The following is a description of a gene set: Genes negatively differentially expressed in cell type: cDC2 (conventional dendritic cell type 2) upon treatment with cytokine: NP in mouse lymph nodes in vivo. studied in species Mus musculus Mouse Gene Set: CUI_CDC2_NEUROPOIETIN_RESPONSE_DN Cytokines mediate cell-cell communication in the immune system and represent important therapeutic targets. A myriad of studies have highlighted their central role in immune function, yet we lack a global view of the cellular responses of each immune cell type to each cytokine. To address this gap, the authors created the Immune Dictionary, a compendium of single-cell transcriptomic profiles of more than 17 immune cell types in response to each of 86 cytokines (>1,400 cytokine-cell type combinations) in mouse lymph nodes in vivo. A cytokine-centric view of the dictionary revealed that most cytokines induce highly cell-type-specific responses. For example, the inflammatory cytokine interleukin-1β induces distinct gene programmes in almost every cell type. A cell-type-centric view of the dictionary identified more than 66 cytokine-driven cellular polarization states across immune cell types, including previously uncharacterized states such as an interleukin-18-induced polyfunctional natural killer cell state. from publication Cui A, Huang T, Li S, Ma A, Pérez JL, Sander C, Keskin DB, Wu CJ, Fraenkel E, Hacohen N (PMID 38057668), and this is the list of marker genes: Btg2, Fos, Mbnl1, Zfp36, Tbc1d4, Atf3, Jun, Fosb, Neat1, Xist, Hspa1b, Dusp1, Pmaip1